Given this list of marker genes Vcl, Mpp7, Dlg5, Actb, Dsg3, Tjp1, Scrib, here is a description of the gene set: Any process in which a protein is transported to, and/or maintained at the adherens junction. Mouse Gene Set: GOBP_PROTEIN_LOCALIZATION_TO_ADHERENS_JUNCTION species: Mus musculus